The following is a description of a gene set: Catalysis of the reaction: an N-acyl-L-amino acid + H2O = a carboxylate + an L-amino acid. Mouse Gene Set: GOMF_AMINOACYLASE_ACTIVITY studied in species Mus musculus, and this is the list of marker genes: Aspa, Cat, Acy3, Pm20d1, Acy1